The following is a description of a gene set: Human Gene Set: GOMF_WATER_TRANSMEMBRANE_TRANSPORTER_ACTIVITY studied in species Homo sapiens Enables the transfer of water (H2O) from one side of a membrane to the other., and this is the list of marker genes: PDPN, AQP10, AQP12B, AQP3, AQP1, AQP12A, SLC4A11, AQP5, AQP6, AQP8, SLC5A1, AQP4, AQP9, AQP11, SLC14A1, AQP7B, AQP7, AQP2, MIP